The following is a description of a gene set: species: Homo sapiens Muscle hypertrophy affecting the calf muscles. Human Gene Set: HP_CALF_MUSCLE_HYPERTROPHY Calf muscle hypertrophy, and this is the list of marker genes: TTN, GMPPB, POMGNT1, SGCG, CAV3, FRG1 (FSHD region gene 1), CAPN3, HMGCR, MYF6, SMN1 (NCBI Gene Id 91918), PLEC, DHX16, POMT1, DAG1, ANO5, SGCB, DMD, MAP3K20, DNM2, PMP22, CNBP, FKTN, LARGE1, MICU1, PLIN1, MYH7, POMT2, LIMS2, BIN1, SGCD, RYR1, KCNA1, AR, SGCA, MTMR14, LAMA2, DPM3, LTBP4, CRPPA, CHCHD10, TCAP, CIDEC, POPDC3, POMGNT2 (NCBI Gene Id 84892), VAPB, DYSF, UNC45B, SPG11, LMNA, FKRP, SLC25A1